The following is a description of a gene set: A localized myotonic contraction in a muscle in reaction to percussion (tapping with the examiner's finger, a rubber percussion hammer, or a similar object). Percussion myotonia Human Gene Set: HP_PERCUSSION_MYOTONIA studied in species Homo sapiens, and this is the list of marker genes: CAV3, CAVIN1, HSPG2, SVIL, CLCN1, SCN4A, ATP2A1, DNAJB6, COX11, HINT1